Given this list of marker genes STXBP1, SLC26A2 (NCBI Gene Id 1836), GPC6, MYOT, FZD2, KCNK9, LMX1B, PTH1R, CHST3, ASXL1, here is a description of the gene set: Human Gene Set: HP_LIMITED_ELBOW_FLEXION Limited elbow flexion studied in species Homo sapiens